The following is a description of a gene set: Human Gene Set: GOBP_RIBOSOMAL_LARGE_SUBUNIT_EXPORT_FROM_NUCLEUS The directed movement of a ribosomal large subunit from the nucleus into the cytoplasm. studied in species Homo sapiens, and this is the list of marker genes: NUP88, XPO1, SDAD1, RBM10, NPM1, NMD3, RAN, MDN1